The following is a description of a gene set: Mouse Gene Set: GOBP_MESENCHYME_DEVELOPMENT studied in species Mus musculus The process whose specific outcome is the progression of a mesenchymal tissue over time, from its formation to the mature structure. A mesenchymal tissue is made up of loosely packed stellate cells., and this is the list of marker genes: Mark1, Fgf8, Gbx2, Trim28, Grem1 (gremlin 1, DAN family BMP antagonist), Aplf, Sema6a, Mdk, Ezh2, Exoc4, Sema3e, Cdh2, Col1a1, Hnrnpab (heterogeneous nuclear ribonucleoprotein A/B), Acvr1, Hes1, Mcrip1 (NCBI Gene Id 192173), Gata5, Pdcd6, Il17rd, Amer1, Edn1, Adam8, Phldb2, Rps7, Myc, Wnt16, Bcl9l, Tead2, Wnt2, Acvrl1, Tbx2, Pax1, Pax2, Foxa1, Wwtr1, Actg2, Agt, Rbm24, Spred3, Bmpr1a, Chrd, Foxa2, Sema3g, Six4, Tsc2, Smo, Fendrr, Rgcc (regulator of cell cycle), Fbxo11, Meox1, Nog, Dlg5, Ptk7, Hnf1a, Tasor, Bmpr2, Wt1 (WT1 transcription factor), Spry1, Nodal, Sdcbp, Sema7a, Zeb2, Fgf10, Qki, Clasp1, Fgf15, Sox4, Prickle1, Mad2l2, Sema3f, Nkx2-1, Smad2, Sema3b, Hand1, Ext1, Slc39a10, Ddx5, Kbtbd8, Lama5, Spsb3, Eomes, Zfp36l1, Nckap1, Acta1, Epha4, Sema3c, Mapk1, Ppp2ca, Fgfr2, Ager, Vangl2, Rock2, Tmem100, Tbx20, Polr1b, Six2, Zic3, Plaur, Wnt3a, Itga4, Klhl12, Hey1, Foxc1, Sema4b, Fn1, Dag1, Nolc1, Zfp750, Gsc (NCBI Gene Id 14836), Kat8, Mtor, Pten, Loxl2, Loxl3, Spred1, Dab2, Snai1, Has2, Tbx1, Sox9, Dppa4, Trip10, Bmp2 (bone morphogenetic protein 2), Ell3, Pax3, Epha3, Tbx3, Trim62, Tgfbr2, Wnt11, Crb2, Radil (NCBI Gene Id 231858), Hmga2, Nup133, Timp3, Kdm1a, Sfrp2, Bmp7, Pdcd4, Ddx17, Heyl, Sema3a, Adipor1, Spred2, Adamts5, Sema6c, Tgfbr3, Rxra, Dppa2, Cyp26c1, Twist1, Flna, Tgfb3, Clasp2, Il1b, Sema5b, Sdhaf2, Fbxl17, Smad7, Dand5, Rock1, Mapk3, Ovol2, Nedd4, Gsk3b, Folr1, Sp6 (trans-acting transcription factor 6, NCBI Gene Id 83395), Ldlrad4 (low density lipoprotein receptor class A domain containing 4), Pef1, Eng, Rflnb, Isl1, Six1 (sine oculis-related homeobox 1), Tapt1, Rbpj, Fuz, Cited2, Fgf9, Thbs1, Acta2 (actin alpha 2, smooth muscle, aorta), Edn3, Dsg2, Ankrd11 (NCBI Gene Id 78664), Dact3 (dishevelled-binding antagonist of beta-catenin 3), Ctnnb1, Ret, Gja1, Phldb1, Ptk2, Nrp2, Adam15, Tcf7l2, Poglut1, Sema4d, Tbx5, Rian, Sema4a, Lrp6, Osr1, Sema3d, Fermt2 (NCBI Gene Id 218952), Otud5, Gata3, Sema6d, Smad3, Tiam1, Zic2, Slc39a6, Foxd1, Cplane2, Tcf21, Smad4, Scx, Nfatc1, Tgfbr1, Bambi, Hand2, Bcl2, Hif1a (NCBI Gene Id 15251), Il6, Frzb, Snai2, Sema6b, Cyp26a1, Cul7, Ranbp3l, Actc1, Gata4, Sema4g, Sox10, Shh, Amh, Aplnr, Akna, Nkx2-5, Phactr4, Bmp5, Arb2a, Pkd2, Tgfbr3l, Msx1 (NCBI Gene Id 269644), Rtn4, Ednrb, Alx1, Pdpn, Htr2b, Cfl1, Erbb4, Pofut2, Fam83d, Tfap2a, Myocd (NCBI Gene Id 214384), Foxf1, Notch1, Nrtn, Dicer1, Pax6, Vasn, Tgfb1, Ppp3r1, Pawr, Usf3 (NCBI Gene Id 74501), Tcf15, Hey2, Bnc2, Hoxa5, Jag1, Sema4c, Ncam1, Gcnt2 (NCBI Gene Id 78281), Vegfa, Axin2, Zic5, Gdnf, Bmp4, Msx2, Wnt5a, Spry2, Wnt4, Mir452, Emp2, Aldh1a2, Robo2, Erbb3, Nrp1, Mdm4, Wnt7b (NCBI Gene Id 22422), Sema4f, Taf10, Sox8, Sema5a, Mef2c, Coro1c, Ednra, Mdm2, Zfp64, Mesp1, Tgfb2, Olfm1, Dll3, Tgfb1i1, Fgfr1, Epb41l5, Efna1, Cdc42, Yap1, Sfrp1, Tcof1, Notch4 (notch 4), Tead1, Foxc2, Htt, Kitl, Hdac2, Wnt10a, Dchs1, Robo1, Stat1, Pitx2, Zfp703 (zinc finger protein 703), Lrg1, Hpn, Efnb1, Glipr2, Rdh10, Nos3, Phox2b, Lef1, Dab2ip